The following is a description of a gene set: Genes down-regulated in comparison of dendritic cells (DC) stimulated with LPS (TLR4 agonist) at 16 h versus DC cells stimulated with CpG DNA (TLR9 agonist) at 16 h. from publication Amit I, Garber M, Chevrier N, Leite AP, Donner Y, Eisenhaure T, Guttman M, Grenier JK, Li W, Zuk O, Schubert LA, Birditt B, Shay T, Goren A, Zhang X, Smith Z, Deering R, McDonald RC, Cabili M, Bernstein BE, Rinn JL, Meissner A, Root DE, Hacohen N, Regev A (PMID 19729616) mouse primary BMDCs were stimulated with tlr ligands and gene expression changes were profiled on Affymetrix arrays studied in species Homo sapiens Human Gene Set: GSE17721_LPS_VS_CPG_16H_BMDC_DN, and this is the list of marker genes: PITRM1, GUCY1A1, NHERF2, PBK, ARHGAP29, UBXN11, SPARCL1, GNA15, SNRPA, CNTN1, LMNA, PLGRKT, MMD2, TCP1, SETD6, UBE2A, PIGO, FIBIN, PTGR1, NUP210, FANK1, SLC39A13, NUDCD3, TRAF4, SLC27A2, S100A9, AK1, DUSP3, SLAIN2, PLA2G4F, RRM2 (ribonucleotide reductase regulatory subunit M2), ZNF808, APOH, SLC5A11, ECHDC2, KIAA1217, EFHD1, SEL1L, CENPK, TEX15, FHL2, CENPN, SCRIB (scribble planar cell polarity protein), KCNA5, RPTN, QTRT1, SYPL1, ESRRB, IL31RA, DNA2, COQ10A, EML3, HTATSF1, COL14A1, KCTD12, RPA3, SLC30A4, INCA1, EGFL7, ZNF821, ALDH7A1, COQ4, SH2D1B, C19orf73, GNG2, SEPTIN8, PABPC4, NSMF, DICER1, CACNA2D1, MYO1B, CCT7, ZNF467, THBS2, NAA38, BRPF1, PLK1, ATG7, SALL2 (NCBI Gene Id 6297), SSR1, ULK2, RAD54L, ACACA (acetyl-CoA carboxylase alpha), TARDBP, LARP7, GNL3, SOX3 (SRY-box transcription factor 3), TIRAP, MS4A10, PRPF6, NEK2, PLRG1, AMH, MAN1A1, UCP1, THYN1, CRELD1, AP2A2, CYP51A1 (cytochrome P450 family 51 subfamily A member 1), CREG1, ADD3, TRAM2, CYB5B, NUTF2, HBB, RBM5, HNRNPK, MICAL1, ABCC1, MFSD6L, MED17, TIMM8A, PRMT7, SYCN, HOXD10, MFGE8, CXCL6, NOP10, TPCN2, MSL1, GFI1B, SOWAHA, NIBAN2, HCN2, CELSR1, DAP3, NCAPG2, SLK, MAGED1, TP53INP2, DPP7, VNN2, CNN1, SPN (sialophorin), CLK2, PRRX2, ST3GAL2, SEPTIN6, RCBTB2, CCDC80, STMN1, CLIC3, LGMN, RITA1, FADS1, BTBD1, OSBPL5, AHCYL1, PYGL, SIDT2, GAPDHS, LGALS3, TBC1D23, G3BP1, C3AR1, CDR2, GRB14 (growth factor receptor bound protein 14), NCR1, DPAGT1, OMD, RAP1A, PPL, NDUFAF7, PPIC, MIB1, UGDH, GRHPR, WBP2, RPL19, SENP3, GRK5, PKP1, PRICKLE1, KIF20A (kinesin family member 20A), PHF10, SERP1, NDUFB8, TXNIP, RPS6KA3, TM7SF3, CD93, PPP1R37, CNTNAP2, TFG, GDAP1L1, SLC35F5, DNAJB8, FSHR, BRIX1, MRPL40, UEVLD, LTF, ASNSD1, ASB17, SEPTIN7, MMUT, GJA4, BICC1, ALAS1, ADGRE1 (adhesion G protein-coupled receptor E1)